The following is a description of a gene set: studied in species Homo sapiens Human Gene Set: GOBP_POSITIVE_REGULATION_OF_THE_FORCE_OF_HEART_CONTRACTION Any process that increases the force of heart muscle contraction., and this is the list of marker genes: RYR2 (NCBI Gene Id 6262), NOS1, SLC8A1, SLC9A1, MYL2